Given this list of marker genes COX6B2, SLC8B1, ATPSCKMT, PTPN1, OPA1, LYN, CIBAR1, TMEM70 (NCBI Gene Id 54968), here is a description of the gene set: Any of the inward folds of the mitochondrial inner membrane. Their number, extent, and shape differ in mitochondria from different tissues and organisms. They appear to be devices for increasing the surface area of the mitochondrial inner membrane, where the enzymes of electron transport and oxidative phosphorylation are found. Their shape can vary with the respiratory state of the mitochondria. Human Gene Set: GOCC_MITOCHONDRIAL_CRISTA studied in species Homo sapiens